The following is a description of a gene set: from publication Chen Y, Wang X (PMID 31504780) Human Gene Set: MIR6769A_3P studied in species Homo sapiens Genes predicted to be targets of miRBase v22 microRNA hsa-miR-6769a-3p in miRDB v6.0 with MirTarget v4 prediction scores > 80 (high confidence targets)., and this is the list of marker genes: NRIP3, ITPRIPL2, ARGLU1, GRIPAP1, ARHGAP35, VCF1, CBLL1, ZNF706, CSNK1G2, GPR107, PKP1, RDH12, BCCIP, KCTD4, SH3BP4, TAB2, AMPD3, EREG, PHF14